The following is a description of a gene set: species: Homo sapiens Reactome Pathway: WNT ligand biogenesis and trafficking part of: Signaling by WNT 19 WNT proteins have been identified in human cells. The WNTs are members of a conserved metazoan family of secreted morphogens that activate several signaling pathways in the responding cell: the canonical (beta-catenin) WNT signaling cascade and several non-canonical pathways, including the planar cell polarity (PCP), the regulation of intracellular calcium signaling and activation of JNK kinases. WNT proteins exist in a gradient outside the secreting cell and are able to act over both short and long ranges to promote proliferation, changes in cell migration and polarity and tissue homeostasis, among others. <br><br><br>The WNTs are ~40kDa proteins with 23 conserved cysteine residues in the N-terminal that may form intramolecular disulphide bonds. They also contain an N-terminal signal sequence and a number of N-linked glycosylation sites. In addition to being glycosylated, WNTs are also lipid-modified in the endoplasmic reticulum by a WNT-specific O-acyl-transferase, Porcupine (PORCN), contributing to their characteristic hydrophobicity. PORCN-dependent palmitoylation is required for the secretion of WNT as well as its signaling activity, as either depletion of PORCN or mutation of the conserved serine acylation site results in the intracellular accumulation of WNT ligand.<br><br><br>Secretion of WNT requires a number of other dedicated factors including the sorting receptor Wntless (WLS) (also knownas Evi, Sprinter, and GPR177), which binds WNT and escorts it to the cell surface. A WNT-specific retromer containing SNX3 is subsequently required for the recycling of WLS back to the Golgi. Once at the cell surface, WNT makes extensive contacts with components of the extracellular matrix such as heparan sulphate proteoglycans (HSPGs) and may be bound by any of a number of regulatory proteins, including WIFs and SFRPs. The diffusion of the WNT ligand may be aided by its packing either into WNT multimers, exosomes or onto lipoprotein particles to shield the hydrophobic lipid adducts from the aqueous extracellular environment.<br><br >, and this is the list of marker genes: WNT10A, WNT6, WNT10B, WNT11, WNT2, WNT7B, WNT9B, WNT3A, WNT8A, VPS26A, WNT2B, WNT5B, WNT9A, WNT7A, VPS29, WNT8B, WLS, WNT5A, WNT1, VPS35, WNT3, WNT4, SNX3, TMED5, PORCN, WNT16